The following is a description of a gene set: species: Homo sapiens Despite their enormous importance, the molecular circuits that control the differentiation of Th17 cells remain largely unknown. Recent studies have reconstructed regulatory networks in mammalian cells, but have focused on short-term responses and relied on perturbation approaches that cannot be applied to primary T cells. Here, we develop a systematic strategy – combining transcriptional profiling at high temporal resolution, novel computational algorithms, and innovative nanowire-based tools for performing gene perturbations in primary T cells – to derive and experimentally validate a temporal model of the dynamic regulatory network that controls Th17 differentiation. The network is arranged into two self-reinforcing and mutually antagonistic modules that either suppress or promote Th17 differentiation. The two modules contain 12 novel regulators with no previous implication in Th17 differentiation, which may be essential to maintain the appropriate balance of Th17 and other CD4+ T cell subsets. Overall, our study identifies and validates 39 regulatory factors that are embedded within a comprehensive temporal network and identifies novel drug targets and organizational principles for the differentiation of Th17 cells. Human Gene Set: GSE43955_TH0_VS_TGFB_IL6_TH17_ACT_CD4_TCELL_30H_UP Genes up-regulated in CD4 T helper cells (30h): Th0 versus TGFB1 and IL6. from publication Yosef N, Shalek AK, Gaublomme JT, Jin H, Lee Y, Awasthi A, Wu C, Karwacz K, Xiao S, Jorgolli M, Gennert D, Satija R, Shakya A, Lu DY, Trombetta JJ, Pillai MR, Ratcliffe PJ, Coleman ML, Bix M, Tantin D, Park H, Kuchroo VK, Regev A (PMID 23467089), and this is the list of marker genes: FABP4, RCAN1, ILF2, PTPN1, DPEP1, VIPR2, BPNT1, COL26A1, STX12, NOP58, IL13RA1, MCM3AP, IL17RA, SLC12A7, LTBP4, CACNA2D1, CCL2, SLC25A51, GTF2F2, HTR2C, PELO, SASH1, JAK2, C5, CEP89, REG1A, CSTF2 (NCBI Gene Id 1478), HOXB13, TNFRSF1A (TNF receptor superfamily member 1A), RNF138, MT2A, SAA2, NFIL3, DYRK1A, FCGR2B, DCLRE1A, GBP4, FGF14, MT1E, BIK, TXNRD1, RMND5A, FURIN, HSD11B1, MYH7, UBXN11, FABP1, FOXN3, CXCL9, CACUL1, MAP3K8, MEST, FAM3B, FASN, DHRS7B, REPS1, MTR, PROCR, DDIT4, AMBN, GBP7, PRX, APOB, POU3F1, B4GALT3, IL6ST, BMP2K, HNF4A, AMBP, EPHA3, NAB1, PLCG1, SEMA6B, APOF, ERRFI1 (ERBB receptor feedback inhibitor 1, NCBI Gene Id 54206), MYD88, NXN, KRTAP13-2, NCR1, GADD45B, CSF2RB, USF1, GJA1, SUSD6, EPB41L4B, RBL2, ZNF398, CMBL, SCG2, GIMAP4, COL11A2, ZC3H3, PIP4K2C, UNG, BACH1, KLHDC2, SERPINE2, CFL2, GRID2 (glutamate ionotropic receptor delta type subunit 2), GALR3, AGFG1, COL3A1, RFLNB, KIF1B, PTCH1, NR5A1, PAH, SELP, FXYD1, RPL13A, GUCA2B, UBE2W, LCP2, GADD45A, SLC4A1, CNOT2, KLRD1, ADGRD1, KRT17, PTGER4, CLCNKB, STX7, ABCD3, PEX5, SEMA3E, RPS29, BAAT, ORC1, IGSF8, NUPR1, FGFR1, TBR1, SLC16A7, DPP8, MAP6, SOCS1, MIDN, MT4, CPNE3, SARS2, TIPARP (TCDD inducible poly(ADP-ribose) polymerase), LIMK2, HAPLN1, SORBS1, ACBD6, SLURP1, IRF1, CDKN2D, SOCS3, LYST, DRD4, PAX5, MET, RAB6A, PLSCR1, IL4R, RHOH, PCNP, CXCL10, SLC38A4, TGFB1I1, BCKDHB, RBMS1, STAT4, NOLC1, FGF11, EIF1AY, MYL6B, TMEM40, PTGS2, CALR (calreticulin), LITAF, CASP4, HOXB6, SOWAHC, CD93, CYP11A1 (cytochrome P450 family 11 subfamily A member 1), RAB18, WDTC1, BATF, SRM, MCOLN2, SFRP1, SLC30A4, RO60 (NCBI Gene Id 6738), DTD2, MAG, XPO6, PTX3, DTNB, CCL7, EHF, FOXQ1, SH3BGRL3, CCL4, COL13A1 (NCBI Gene Id 96775), CH25H, TIRAP, KLF5, RPGR